Given this list of marker genes AKAP5, ADISSP, AKAP12, FSHR, AKAP6, PJA2, TCIM, ADGRV1, here is a description of the gene set: species: Homo sapiens Human Gene Set: GOBP_REGULATION_OF_PROTEIN_KINASE_A_SIGNALING Any process that modulates the rate, frequency, or extent of protein kinase A signaling. PKA signaling is the series of reactions, mediated by the intracellular serine/threonine kinase protein kinase A, which occurs as a result of a single trigger reaction or compound.